Given this list of marker genes EXOC7, EXOC2, ITGAV, KRT6A, FUCA2, CAV1, CXCL8, here is a description of the gene set: Human Gene Set: GOBP_REGULATION_OF_ENTRY_OF_BACTERIUM_INTO_HOST_CELL Any process that modulates the frequency, rate or extent of entry of bacterium into host cell. species: Homo sapiens